The following is a description of a gene set: studied in species Mus musculus Mouse Gene Set: GOBP_PRE_B_CELL_DIFFERENTIATION The process in which a precursor cell type acquires the specialized features of a pre-B cell. Pre-B cells follow the pro-B cell stage of immature B cell differentiation and undergo rearrangement of heavy chain V, D, and J gene segments., and this is the list of marker genes: Rag1, Cd24a, Atp11c, Mir92-1, Ighm, Foxp1, Laptm5, Mir19b-1, Mir18, Lrrc8a, Atm, Mir17 (NCBI Gene Id 723905), Mir19a, Rag2, Mir20a